The following is a description of a gene set: Normal cells require continuous exposure to growth factors in order to cross a restriction point and commit to cell-cycle progression. This can be replaced by two short, appropriately spaced pulses of growth factors, where the first pulse primes a process, which is completed by the second pulse, and enables restriction point crossing. Through integration of comprehensive proteomic and transcriptomic analyses of each pulse, we identified three processes that regulate restriction point crossing: (1) The first pulse induces essential metabolic enzymes and activates p53-dependent restraining processes. (2) The second pulse eliminates, via the PI3K/AKT pathway, the suppressive action of p53, as well as (3) sets an ERK-EGR1 threshold mechanism, which digitizes graded external signals into an all-or-none decision obligatory for S phase entry. Together, our findings uncover two gating mechanisms, which ensure that cells ignore fortuitous growth factors and undergo proliferation only in response to consistent mitogenic signals. Class II of genes transiently induced by EGF in 184A1 cells (mammary epithelium). studied in species Homo sapiens from publication Zwang Y, Sas-Chen A, Drier Y, Shay T, Avraham R, Lauriola M, Shema E, Lidor-Nili E, Jacob-Hirsch J, Amariglio N, Lu Y, Mills GB, Rechavi G, Oren M, Domany E, Yarden Y (PMID 21596316) Human Gene Set: ZWANG_CLASS_2_TRANSIENTLY_INDUCED_BY_EGF, and this is the list of marker genes: INHBA, TAF1D (TATA-box binding protein associated factor, RNA polymerase I subunit D), HOXB8, NAB2, FSTL1, SPOCD1, ENC1 (ectodermal-neural cortex 1), KLF10, ZNF189, CHIC2 (cysteine rich hydrophobic domain 2), HOXC13, PXDC1, EGR1, ERRFI1, TAGLN, SPHK1, DZIP1L, SMAP1, PRXL2C, F3, CLIC3, GFPT2, LMNTD1, OSR1, CITED2, CLCF1 (cardiotrophin like cytokine factor 1), GLS, RNVU1-19, GLIPR1, CDC42EP2, RNVU1-15, JAM2, ARHGAP29, FHDC1, ARL14, ANXA2P3, CCN2, LY6G6C, PAX9, CCNJ, BLID, RGCC, RNU6-957P, IL7, KIR2DL4, EGR3, LIFR, PTHLH, HSPA8, KLF5 (NCBI Gene Id 688), RNF24, CLK1, HS3ST1, KRTAP2-4